Given this list of marker genes Aldoa, Pgk1, Mdh2, Pcx, Cacna1h, Mdh1, Bmp5, Cyp11b1, Clcn2, Bmp2, Wnt4, Pdxk, Bmp6, Dab2, Pgam1, Gapdh, Pnpo, Eno1, Cyp11b2, Tpi1, Rest, Pck1, Gpd1, Dkk3, Kdm3a, Tkt, Slc25a10 (NCBI Gene Id 27376), here is a description of the gene set: The chemical reactions and pathways resulting in the formation of aldehydes, any organic compound with the formula R-CH=O. Mouse Gene Set: GOBP_ALDEHYDE_BIOSYNTHETIC_PROCESS studied in species Mus musculus